Given this list of marker genes OCA2, KIT, MC1R, TYR, TYRP1, here is a description of the gene set: Human Gene Set: HP_ABSENT_SKIN_PIGMENTATION Lack of skin pigmentation (coloring). Absent skin pigmentation species: Homo sapiens